The following is a description of a gene set: Catalysis of the transfer of a phosphate group to a histone H3. Human Gene Set: GOMF_HISTONE_H3_KINASE_ACTIVITY species: Homo sapiens, and this is the list of marker genes: RPS6KA4, AURKA, PRKCB, DYRK1A, PRKCA, PKM, CHEK1, HASPIN, VRK1, RPS6KA5, JAK2, PKN1